Given this list of marker genes Wsb2, Amotl2, Ugcg, Fermt2, Bod1l, Ext1, Col5a2, Atxn2, Sh3glb1, Nr2f2, Vcam1, Vcl, Igf1r, Lpp, Rock1, Wsb1, Ppp1cb, Sc5d, Xbp1, Ssb, Klf6, Prss23, F3 (NCBI Gene Id 99486), Acta2, Col4a1, Tpm1, Dock5, Pdlim7, Egr1, Myh9, Abracl, Fasn, Klf5, Ier2, Wwc2, Col4a2, Kat2b, Sf3b1, Sparc, Actc1, Nrp1, Myl12a, Luc7l3 (LUC7-like 3 (S. cerevisiae)), Jade1, Csf1, Pawr, Hspa5, Qki, here is a description of the gene set: species: Mus musculus Genes down-regulated in NIH3T3 cells (fibroblasts) after treatment with Y27632, an inhibitor of ROCK proteins; the changes did not depend on expression of constitutively active (Q63L) form of RHOA. Mouse Gene Set: BERENJENO_ROCK_SIGNALING_NOT_VIA_RHOA_DN from publication Berenjeno IM, Núñez F, Bustelo XR (PMID 17213802) We have used microarray technology to identify the transcriptional targets of Rho subfamily guanosine 5'-triphosphate (GTP)ases in NIH3T3 cells. This analysis indicated that murine fibroblasts transformed by these proteins show similar transcriptomal profiles. Functional annotation of the regulated genes indicate that Rho subfamily GTPases target a wide spectrum of functions, although loci encoding proteins linked to proliferation and DNA synthesis/transcription are upregulated preferentially. Rho proteins promote four main networks of interacting proteins nucleated around E2F, c-Jun, c-Myc and p53. Of those, E2F, c-Jun and c-Myc are essential for the maintenance of cell transformation. Inhibition of Rock, one of the main Rho GTPase targets, leads to small changes in the transcriptome of Rho-transformed cells. Rock inhibition decreases c-myc gene expression without affecting the E2F and c-Jun pathways. Loss-of-function studies demonstrate that c-Myc is important for the blockage of cell-contact inhibition rather than for promoting the proliferation of Rho-transformed cells. However, c-Myc overexpression does not bypass the inhibition of cell transformation induced by Rock blockage, indicating that c-Myc is essential, but not sufficient, for Rock-dependent transformation. These results reveal the complexity of the genetic program orchestrated by the Rho subfamily and pinpoint protein networks that mediate different aspects of the malignant phenotype of Rho-transformed cells.